Given this list of marker genes MIR155HG, MS4A7, HRH1, PLA2G7, PLB1, CFP, CASP1, CSF1R, LINC01725, IGSF6, CD163L1, CD1C, HLA-DPA1, IRF5, CABLES1, CIITA, ZNF710, NCF4, SIGLEC11, CD209, ENSG00000253557, SIGLEC1, SMIM35, MCOLN2, FMN1, HPGDS, LINC01503, CD74, P2RY13, CLEC7A, GLT1D1, C3AR1, HLA-DQB1, TLR1, TRPM2, ARHGAP22, SLC7A8, P2RY6, PLD4, HLA-DPB1, ENSG00000261460, CYBB, CSF2RA, CR1, HCK, MERTK, ZEB2-AS1, SPI1, LINC03070, FAM20A, AIF1, NOXA1, LILRB5, RASGRP4, FOLR2, HLA-DRB1 (NCBI Gene Id 730415), MS4A4A, CD86, MNDA, KYNU, CYTH4, FLT3, RBM47, CMKLR1, C9, CYTIP, LINC00671, S100A9, IRF8, RGL1, KCNE1, LY75, MYOSLID-AS1, UNC93B1, MS4A6A, FGD2, GLIPR1, SIRPB2, CD83, C1QA, CD163, NCF2, RBPJ, HLA-DMA, HLA-DRB6, IL10RA, VSIG4, JAML, LY86, EAF2, SEMA4A, GNA15, LHCGR, AGR2, CST3, CHN2, LINC02649, CD14, MFSD13A, LYZ, LINC00278, HLA-DRA, CD200R1, NAPSB, TEC, C1QC, RENBP, GPBAR1, ADAP2, ITGAM, SPP1, LACC1, WWP1, DNAI3, ST18, TLR2, RTN1, MKNK1, TLR6, RPH3AL-AS1, NFAM1 (NCBI Gene Id 150372), C2, DNASE1L3, HMOX1, BLNK, CCDC170, CTSS, MS4A4E, FCN1, PIPOX (pipecolic acid and sarcosine oxidase), ATP8B4, HLA-DQA1, FGL1, here is a description of the gene set: Human Gene Set: DESCARTES_FETAL_MUSCLE_MYELOID_CELLS Marker genes curated from the annotated cluster as represented in the Descartes Human Gene Expression During Development database. from publication Cao J, O'Day DR, Pliner HA, Kingsley PD, Deng M, Daza RM, Zager MA, Aldinger KA, Blecher-Gonen R, Zhang F, Spielmann M, Palis J, Doherty D, Steemers FJ, Glass IA, Trapnell C, Shendure J (PMID 33184181) species: Homo sapiens The gene expression program underlying the specification of human cell types is of fundamental interest. The study authors generated human cell atlases of gene expression and chromatin accessibility in fetal tissues. For gene expression, the study authors applied three-level combinatorial indexing to >110 samples representing 15 organs, ultimately profiling ~4 million single cells. The study authors leveraged the literature and other atlases to identify and annotate hundreds of cell types and subtypes, both within and across tissues. Our analyses focused on organ-specific specializations of broadly distributed cell types (such as blood, endothelial, and epithelial), sites of fetal erythropoiesis (which notably included the adrenal gland), and integration with mouse developmental atlases (such as conserved specification of blood cells). These data represent a rich resource for the exploration of in vivo human gene expression in diverse tissues and cell types.